Given this list of marker genes POLR2I, GPS1, XPA, AQR, CCNH, POLR2B, UVSSA, USP7, ERCC8, TCEA1, COPS7B, POLR2H, POLR2G, POLR2D, CUL4B, PRPF19, POLR2C, GTF2H3, GTF2H1, GTF2H5, COPS7A, COPS4, COPS5, COPS3, XAB2, ERCC3, RBX1, GTF2H4, GTF2H2, UBA52, POLR2A, PPIE, POLR2K, RPS27A, UBB, POLR2E, ERCC6, MNAT1, POLR2L, CDK7, POLR2J, ERCC2, DDB1, COPS6, ZNF830, CUL4A, COPS2, UBC, ISY1 (ISY1 splicing factor homolog), POLR2F, COPS8, here is a description of the gene set: part of: Transcription-Coupled Nucleotide Excision Repair (TC-NER) species: Homo sapiens Reactome Pathway: Formation of TC-NER Pre-Incision Complex Formation of TC-NER pre-incision complex is initiated when the RNA polymerase II (RNA Pol II) complex stalls at a DNA damage site. The stalling is caused by misincorporation of a ribonucleotide opposite to a damaged base. Cockayne syndrome protein B (ERCC6, CSB) binds stalled RNA Pol II and recruits Cockayne syndrome protein A (ERCC8, CSA). ERCC8 is part of an ubiquitin ligase complex that also contains DDB1, CUL4A or CUL4B and RBX1. This complex is implicated in the regulation of TC-NER progression probably by ubiquitinating one or more factors involved in this pathway, which may include RNA Pol II and ERCC6 at the later stages of repair. XPA is recruited to the TC-NER site through its interaction with the TFIIH complex. The XAB2 complex, which probably regulates the accessibility of the DNA damage site through its RNA-DNA helicase activity, binds the TC-NER site via the interaction of its XAB2 subunit with RNA Pol II, ERCC6, ERCC8 and XPA. TCEA1 (TFIIS) is a transcription elongation factor that may facilitate backtracking of the stalled RNA Pol II, enabling access of repair proteins to the DNA damage site and promotes partial digestion of the 3' protruding end of the nascent mRNA transcript by the backtracked RNA Pol II, allowing resumption of RNA synthesis after damage removal. Access to DNA damage sites in TC-NER was suggested to be facilitated by a chromatin remodeler HMGN1, but another sudy found that HMGN1 was not needed for human TC-NER. UVSSA protein interacts with ubiquitinated ERCC6 and RNA Pol II, recruiting ubiquitin protease USP7 to the TC-NER site and promoting ERCC6 stabilization.